Given this list of marker genes Xrcc1, Cd38, Oxr1, Trp53inp1, Sp1, Sin3a, Prkd1, Rnf112, Ddias, Cd36, Jak2 (NCBI Gene Id 98155), Gpx1, Apoa4, Dapk1, Trpm2, Mgst1, Prkcd (NCBI Gene Id 52581), mt-Nd1, Tmigd1, here is a description of the gene set: Any process that results in a change in state or activity of a cell or an organism (in terms of movement, secretion, enzyme production, gene expression, etc.) as a result of a hydroperoxide stimulus. Hydroperoxides are monosubstitution products of hydrogen peroxide, HOOH. Mouse Gene Set: GOBP_RESPONSE_TO_HYDROPEROXIDE species: Mus musculus